Given this list of marker genes KLHL7, TTC3, CYBC1, SUPT16H, ATP5MC3, SLC39A1, ZNF830, PANK3, SRSF6 (serine and arginine rich splicing factor 6), BCDIN3D, GALK2, FZR1, HTATIP2, SDHD, RPN1, DUS1L, GTF3C4, UBE2J1, RCOR1, PTPMT1, MMACHC, ETFBKMT, RAB40C, DDHD2, PCMTD2, ATG5, CDC42SE2, PPP1CC, EEF1B2, ARAP1, HMGCS1, GNG10, SPIC, C18orf32, MEF2D, MRPL51, RPF2, POLR2E, RPL3, MIA3, P2RY6, WDR45B, GRK6, TMEM101, CSE1L, RNH1, TPRKB, LITAF, TSPAN3, CDK2AP1, MTG2, XPO7, CXCR4, MICU1, ZNF106, SNHG11, ETFRF1 (electron transfer flavoprotein regulatory factor 1), FES, CKLF, ZNF276, MBTD1, YIPF4, RANBP10, MRPL37, TMEM234, HLCS, AKR1B15 (NCBI Gene Id 442622), NFE2L2, PICK1, FERRY3, SEC14L1, STAB1, DUSP1, ZC3H14, CDC25A, CPS1, BHMT2, DAD1, EXOC8, LTN1, LIPA, CLK2, EGLN2, SACM1L (SAC1 like phosphatidylinositide phosphatase), C7orf25, SUN2, NFU1 (NCBI Gene Id 80767), ATP6V1C1, ZXDC, MAPK7, CD1D, ITGB1BP1, PGLYRP2, MAP3K11, FARSB, ELOVL6, IPO9, RPF1, IFNGR2, NDUFA7, B4GALT1, MAGIX, SHC1, NUDCD2, ATP5F1D, TCF12, SKP1 (S-phase kinase associated protein 1), CEBPZ, KATNBL1, RBM3, SMARCC1, SLC6A8, NUP160, SIKE1, TP53INP2, SENP3, GLMP, ATP6V1A, DPEP3, UBE4B, TESK2, PIM3, MRPL40, ANXA3, MBD3, KIF3C, FCHO1, SLC19A2 (solute carrier family 19 member 2), ZNF600, SNX1, MRPS34, REEP5, RRS1, TACC2, ASH2L, PTCD2, PLA2G6, P2RX5, ZNF264, RABGAP1, WIZ, ARL8B, MRPL57, SLC2A1, CEP19, ACSL5, TMEM68, OSBPL2, ATF2, MORF4L1, RBFOX2, RAB3IL1, SACS, KICS2, C19orf53, TMEM222, CTBP1, DPP8, DCTN5, MCFD2, CYB5A, WDR75, HEATR6, TMED7, MRM1, YWHAB, HSP90AA1, INPP5D, GLUD1, KCNJ14, ACAT2, RAB31, RNASEK (NCBI Gene Id 440400), CLUH, POLE3, CSNK2A2, COX19, YPEL3 (NCBI Gene Id 83719, yippee like 3), PTGES3, FGFR1OP2, CALR, RPGRIP1, C6orf136 (chromosome 6 open reading frame 136), CBR1, SARS1, DGKZ, FASN, SLC25A51, MEPCE, ZBTB22, USP39, RASSF5 (Ras association domain family member 5), CHFR, DOLPP1, ARMC7, SIGIRR, SNX15, BIN3 (NCBI Gene Id 55909), SEC16A, here is a description of the gene set: mouse primary BMDCs were stimulated with tlr ligands and gene expression changes were profiled on Affymetrix arrays species: Homo sapiens Genes down-regulated in comparison of dendritic cells (DC) stimulated with LPS (TLR4 agonist) at 4 h versus DC cells stimulated with Pam3Csk4 (TLR1/2 agonist) at 4 h. Human Gene Set: GSE17721_LPS_VS_PAM3CSK4_4H_BMDC_DN from publication Amit I, Garber M, Chevrier N, Leite AP, Donner Y, Eisenhaure T, Guttman M, Grenier JK, Li W, Zuk O, Schubert LA, Birditt B, Shay T, Goren A, Zhang X, Smith Z, Deering R, McDonald RC, Cabili M, Bernstein BE, Rinn JL, Meissner A, Root DE, Hacohen N, Regev A (PMID 19729616)